The following is a description of a gene set: Genes up-regulated in comparison of untreated wild type macrophages at 4 h versus those from IRAK4 deficient mice at 4 h. IRAK-4 is an essential component of the signal transduction complex downstream of the IL-1- and Toll-like receptors. Though regarded as the first kinase in the signaling cascade, the role of IRAK-4 kinase activity versus its scaffold function is still controversial. In order to investigate the role of IRAK-4 kinase function in vivo, ‘knock-in’ mice were generated by replacing the wild type IRAK-4 gene with a mutant gene encoding kinase deficient IRAK-4 protein (IRAK-4 KD). Analysis of bone marrow macrophages obtained from WT and IRAK-4 KD mice with a number of experimental techniques demonstrated that the IRAK-4 KD cells greatly lack responsiveness to stimulation with the Toll-like receptor 4 (TLR4) agonist LPS. One of the techniques used, microarray analysis, identified IRAK-4 kinase-dependent LPS response genes and revealed that the induction of LPS-responsive mRNAs was largely ablated in IRAK-4 KD cells. In summary, our results suggest that IRAK-4 kinase activity plays a critical role in TLR4-mediated induction of inflammatory responses. Human Gene Set: GSE9037_WT_VS_IRAK4_KO_BMDM_UP studied in species Homo sapiens from publication Koziczak-Holbro M, Glück A, Tschopp C, Mathison JC, Gram H (PMID 18266302), and this is the list of marker genes: GPR176 (NCBI Gene Id 11245), FHIP2B, ERGIC2, SMARCA5, TMEM47, UTP11, KLF6 (NCBI Gene Id 8025), PEX19, CDC73, ARMCX2, NUP58, KRT10, TANK (NCBI Gene Id 10010), RIF1, IER3IP1, TGFBI, UBXN6, VDAC1, HAPSTR1, TAX1BP1 (NCBI Gene Id 8887, Tax1 binding protein 1), MRM1, SYNPO2, DMD, PNRC1, JADE1, BDKRB2, SH3BP5, ZBTB26, FGFR2, ABI3, PDE4DIP, KRTAP4-6, YIPF4, CIRBP, FGF7 (NCBI Gene Id 82955), FHL2, FNIP2, GJB4, POLR3C (NCBI Gene Id 10623), IL6ST, GID4, SOCS2, PLAC8, ATF7, ZC2HC1A, VIM, XKR8, SAV1, RPRD2, CHD3, ZNF280C, PCMTD2, TBPL1, VAMP2, B4GALT6, ACAP2, SELENOP (NCBI Gene Id 6414), EIF4E3, ACKR3, PIR, IGF2BP3, PIAS1, AZI2, GSC2, GPCPD1, USP6NL, CBX2, WFS1, TMEM176B, HOXA10, TULP3, TFCP2, PRUNE2, SORD, ARHGAP23, NBEA, CCDC122, MAP3K1, HS6ST2, F2R, ATG13, PRKD3, PDGFRA, ACOT2, IQGAP1, SNX10, EHBP1, CREG1, LIMK2, ACP3, MSRB3, STT3A, CEP83, KLHL20, FAT4, CAAP1, UTP15, CCDC97, NDST1, HMOX1, STIM1, RRN3, PHKG2 (phosphorylase kinase catalytic subunit gamma 2), ZNF546, NFIX, ATG4C, LIN9, AKAP7, MANBAL, ETS1, ACTL6A, CEMIP, MEAK7, C6orf62, CD2AP, PTK2, THBD, USP45, ELF2, GPX8, KCTD16, PFN2, PRKCA, PUS7L, DOC2A, AOX1 (NCBI Gene Id 316), FAM204A, GZF1, USP33, IGFBP7, RCOR3, ALDH3A1, MMACHC, PTGS2, BANF1 (NCBI Gene Id 8815), TERT, RMC1, RALGAPA1, ACBD3 (NCBI Gene Id 64746), HOXC8, NT5DC1 (5'-nucleotidase domain containing 1), JMJD1C, NHERF1, QKI, ZNF469, NRG1, SLC22A5, LLGL1, FAM98B, PDAP1, USP47, PYM1, TWIST1, PWP1, PDP1, ZFP1, NRIP1, CMPK1, ZNF583, KLF10, LYST, KIF3A, CDK12, FABP5, PBX1, LUC7L2, LAMB1, LSM14A, GAS1, DNAJB6, TOX4, ANXA7, WDR55, TTC39A, LONRF3, NR2F2 (nuclear receptor subfamily 2 group F member 2), RP2, KDELR3, SSH1 (NCBI Gene Id 54434), NEMF, FEM1C, NUBPL, CD28, MAT2A, DUS3L, IKBIP, TNFAIP3 (TNF alpha induced protein 3), ZNF385A, OGFOD3, TSHZ3, ZNF438, SERPINB9, CERS6, RC3H2, DDHD1, MFAP5, OSGEPL1, CSF1, METTL5, TBC1D12